Given this list of marker genes Myh7, Gja1, Tcap, Mnat1, Myh6, Aplnr, Nkx2-5, Hand2, Ttn, Myh10, Adra1a, Slc22a5 (solute carrier family 22 (organic cation transporter), member 5), Adra1b, Bmp10 (NCBI Gene Id 12154), Mef2d, Chd7 (chromodomain helicase DNA binding protein 7), Asxl2 (ASXL transcriptional regulator 2), here is a description of the gene set: Mouse Gene Set: GOBP_ADULT_HEART_DEVELOPMENT studied in species Mus musculus The process whose specific outcome is the progression of the adult heart over time, from its formation to the mature structure.